The following is a description of a gene set: Adenylate cyclase activating pathway studied in species Mus musculus Mouse Gene Set: REACTOME_ADENYLATE_CYCLASE_ACTIVATING_PATHWAY, and this is the list of marker genes: Adcy4, Adcy2, Adcy8, Adcy6, Adcy5, Adcy1, Adcy9 (adenylate cyclase 9), Gnal, Adcy3, Adcy7